Given this list of marker genes UROS, IL7R, ABCC6, RPL5, LBR, PEX6, TBCK, TREM2, GBE1, AHCY, PLD1, MAPT, GRIP1, PSEN1, PGAP2, SQSTM1, FGFR3, EIF4H, BRD4, COL11A1, CBL, HNRNPK, CHD7, ADA2, PEX3, TWIST2, WASHC5, MKS1, PEX26 (NCBI Gene Id 55670), IL2RG, ELN, CSGALNACT1, DHPS, CHRNG, ZSWIM6 (NCBI Gene Id 57688), PMM2, IFT80, WNT7A, ITPR1, RPS26, NR1H4, WWOX, GATB, SLC30A9, SMC1A (structural maintenance of chromosomes 1A), LYN, RPS7, FANCB, GATA6, ESAM, HRAS, HEATR3, HSD17B4, FOXF1, MYL11, BUB1B, MAX, GATC, RPS10 (ribosomal protein S10), NEU1, PEX16, TGM1, COL1A1, KLF1, GTF2IRD1, CLCN3 (NCBI Gene Id 133073), PEX10, HBA2, RAG1, SLC26A2, QRICH1, SPECC1L, RAB34, SPTB, MRPS16 (mitochondrial ribosomal protein S16), KIAA0586, LRPPRC, EPB41, BNC2, CCDC22, CLXN, GLB1, ALPK3, ADARB1, PEX11B, RASA1, TRIP13, RNU4-2, RRAGC, PIEZO1, BMPER (NCBI Gene Id 168667), RYR3, FANCF, PKLR, SOS2, TMEM270, ASAH1, DOHH, DHCR7, NDUFB10, KRAS, STS, FKBP6, VPS37D (VPS37D subunit of ESCRT-I), PIGV, NCF1, RMRP, GTF2IRD2, FASLG, FAS, BSND, HPS6, LZTR1, SLC35D1, TRIM37, LIG4, GTF2I, DPYSL5, RPL9, PTPN11, ATP6V1B2, DDX6, FRAS1, ZNF699 (zinc finger protein 699), QRSL1, DCLRE1C, MGAT2, BUD23, BUB1, PAK2, SMC3, GAA, MCM10, POR, SLC17A5, DYNC2I2, HLCS, FGF13, TMEM106B, TAPT1, CDC42BPB, SLC31A1, CRLS1, ODC1, RAD21, TTC7A (tetratricopeptide repeat domain 7A), FLNB, NPC1, VAC14, TAF6, TALDO1, RAP1B, RHD, PTH1R, ALG1, VPS35L, DNAJC30, RPS29, EPHB4, METTL27, FIG4, ZIC3, NIPBL, RPS20, ARSL, CAPRIN1, WDR35, STX1A, FBXL4, CHMP2B, RPS28, RAF1, CRB2, FAT4, LARS2, TSR2, GRN, ADGRG6, CTSA, PI4KA, DPF2, MYL9, MYH7, KMT2D, TCF4, NEK9, KIF20A, RPL27, FLT4, CARS2, HSPG2, PEX2, TBL2, EFNB1, PIGY, MYT1L, NRAS, THSD1, RPL11, SCN4A, TRIP11, RPL8, COL1A2, B9D1, ASXL2, ALG8, PIGL, SCN5A, PIK3CA, COG8, PEX13, TBC1D24, MCTP2, RPL26 (NCBI Gene Id 6154), NEK1, RPL31, PIGO, FLG, SLC27A4, GUSB, RPS27, RRAS2, CDAN1, COL2A1, GATA1, PIGA, PSAT1, DYNC2H1, RPL15, PEX19, RAC1, MUSK, SPRED2, CALCRL, MRAS, PEX12, RRAS, STAG1, FH, EBP, NSF, LAMA5, RPS24, RYR1, HADHA, PEX1, RNU4ATAC (NCBI Gene Id 57788), HDAC8 (NCBI Gene Id 7492), RIT1, PEX5, RAG2, GNB2, BUB3, BAZ1B, ZBTB18, MECOM, CACNA1C, WNT4, PGAP3, PIGN (NCBI Gene Id 23556), AGGF1, HOXD13, MDFIC, KANSL1, LIMK1, ATN1, RASA2, RFC2, EIF5A, PACS1, ENPP1, KIF26A, SOS1 (SOS Ras/Rac guanine nucleotide exchange factor 1), SCARF2, RPS19 (NCBI Gene Id 8378), WNT3 (Wnt family member 3), WT1, RPS17, NPC2, DYNC2I1, RPL35A (NCBI Gene Id 6165), VCP (NCBI Gene Id 94731), CCBE1, PEX14, CEP57, HBA1, DOCK11, GBA1, SPTA1, GYPC, GPC6, ADAMTS3, FOXC2 (NCBI Gene Id 50824), UROD, TXNDC15, SOX18, SLC35A2, NUP88, MRPS22, PPP3CA, TLK2, CLIP2, ZBTB42, ALG9, RPS15A, MMACHC, CASP10, TRAF7, PIGW, RPL18, ADA, RPL35, here is a description of the gene set: Abnormal fetal morphology species: Homo sapiens Any structural anomaly of the fetus. Human Gene Set: HP_ABNORMAL_FETAL_MORPHOLOGY